The following is a description of a gene set: Mouse Gene Set: GOCC_U2_TYPE_CATALYTIC_STEP_2_SPLICEOSOME A spliceosomal complex that contains the U2, U5 and U6 snRNPs bound to a splicing intermediate in which the first catalytic cleavage of the 5' splice site has occurred. The precise subunit composition differs significantly from that of the catalytic step 1, or activated, spliceosome, and includes many proteins in addition to those found in the U2, U5 and U6 snRNPs. studied in species Mus musculus, and this is the list of marker genes: Rbm22, Cwc22rt4, Snrpd1, Cdc5lrt1 (NCBI Gene Id 668180), Cdc40, Cwc22rt6, Cdc5lrt7, Cwc22rt1, Cdc5l, Prpf8, Srrm2, Bud31, Syf2, Cwc22, Cdc5lrt10, Cdc5lrt6, Snrpe, Xab2, Cwc22rt7, Snrpb, Cdc5lrt9, Bcas2, Ppie, Snrpf, Plrg1, Cwc22rt5, Cwc15, Snrpd2, Dhx8, Snw1 (NCBI Gene Id 66354), Snrpd3, Snrpb2, Snrnp40, Cwc22rt3, Cdc5lrt4, Cwc22rt2, Cdc5lrt5, Cdc5lrt8, Tex16, Ppil1, Prpf19, Crnkl1, Aqr, Eftud2, Snrpa1, Snrpert, Snrpg